Given this list of marker genes CD200, CLSTN3, CNTN4, ANXA2, PKP3, CNTN5, S100A11, KRT18, DSP, STXBP6, CTNND1, PAK4, ROBO4, TRIM29, TMIGD1, CDH5, ROBO3, BAIAP2, PDLIM1, GLDN, IZUMO1, ESAM, PLXNB3, CLDN3, PALLD, IGSF9, EMB, CDC42EP1, CNTN2, EPCAM, CD47, PKP2, PDLIM5, DSCAM, NEXN (nexilin F-actin binding protein), DSCAML1, NTNG1, DSG2, RAB10, ANXA1, CNN3, SIRPA, CXADR, PPP1CA, MYPN, CNTN1, CLDN19, DSC2, NPTN, JUP, BAIAP2L1, LRRC4C, BSG, NRCAM, NFASC, JAM3, CNTN6, TMOD3, here is a description of the gene set: species: Homo sapiens The binding by a cell-adhesion protein on the cell surface to an extracellular matrix component, to mediate adhesion of the cell to another cell. Human Gene Set: GOMF_CELL_CELL_ADHESION_MEDIATOR_ACTIVITY